The following is a description of a gene set: Systems vaccinology has emerged as an interdisciplinary field that combines systems wide measurements and network and predictive modeling applied to vaccinology. Here we used the systems vaccinology approach to study the molecular mechanisms underlying the innate responses to the trivalent inactivated influenza (TIV) and live attenuated influenza (LAIV) vaccination in humans, and to identify early gene signatures that predict the magnitude of the antibody responses to influenza vaccination. Genes down-regulated in comparison of peripheral blood mononuclear cells (PBMC) from TIV influenza vaccinee pre-vaccination versus that after the vaccination Human Gene Set: GSE29614_CTRL_VS_TIV_FLU_VACCINE_PBMC_2007_DN from publication Nakaya HI, Wrammert J, Lee EK, Racioppi L, Marie-Kunze S, Haining WN, Means AR, Kasturi SP, Khan N, Li GM, McCausland M, Kanchan V, Kokko KE, Li S, Elbein R, Mehta AK, Aderem A, Subbarao K, Ahmed R, Pulendran B (PMID 21743478) species: Homo sapiens, and this is the list of marker genes: ADAMTSL2, CRYBB1, ZWINT, TNFRSF17, GRHL3, CEP162, TCP10L3, ADAMTSL4, SPC24, KIF14, TMEM19, DMBT1, PHF8, CFB, IGLV1-44, PRSS50, RAB40C, ZBTB8A, CEP70, SLC22A1, TEF, KCNIP4, STK31, KIF28P, STATH, PHYHIPL, DNAJC25, RFESD, PRR7-AS1, OXGR1, CAV1, PDZK1, IQCF6, GINS1 (NCBI Gene Id 9837), SDHA, HMMR, FAM98A, RNF170, DDX17, EXTL3-AS1, MIR124-2HG, FABP4 (fatty acid binding protein 4), SLC2A5, FSCN3, SEMG1, GULP1, RBM26-AS1, AURKA, SLC9B1, XBP1, ITM2C, STX19, TYMS, MSX1, SORCS3, EFHC1, CCDC167, ANO4, EMC9, IZUMO1, MRPS7, CFAP300, PLPPR5-AS1, TPD52, SPAG5, DLGAP5, CFAP20, SPATA31E1, KHDC1, ODR4, PALD1, SEC11C, CHAC2, DSN1, ADIPOQ, CEP55, NCAPG, MRPL35, POU4F1, LINC02226, ZC3HAV1L, STEAP1 (NCBI Gene Id 26872), FOXM1, ASIC5, CCNB2, ZNF99 (zinc finger protein 99), HSD17B6, CDK1, IGLV3-19, CPNE4 (copine 4), WWC1, CENPF, BHLHE41, CD38, ENSG00000124835, E2F8, CD1E, NUF2, KIF20A, MZB1, ZNF625, SPIC, MCM2, EXD3, IGLL3P, NTNG1, DTL, CCNB1, H4C9, CDC27, B4GALT3, SRARP, ADD2, OR52A1 (NCBI Gene Id 23538), SMC2, MAGEB18, PURPL, SEMG2, OIP5, PCDH12 (protocadherin 12), PRDM15, PBK, ASB3, HSP90B1, SEC24C, NT5DC2, PARM1, TUBG1, ANKRD16, TMEM168, CNTNAP3, SHROOM2, CABP1, MRPL12, XKR6, HSPA5, ZCCHC2, AMN, SCOC-AS1, IGLJ3 (NCBI Gene Id 28831), BFSP2, EOLA2, ZNF257, BUB1B, GMPPB, TRAM2, CLPTM1L, DENND5B, GLDC, UMODL1, TRIP11, LINC00472, DMGDH, CST1, ZNF22-AS1, SIGLEC6, KIF15, ABRA, SLC25A5-AS1, CDKN3, GUSBP11, RRM2, SHCBP1, MINAR1, PRPF38A, FANCM, TMPRSS11E, LINC00616, GPHB5, GLI2, ABCA8, YTHDF1, TPM4, PCLAF, TAS2R40, PPP4R3C, SAXO2, RGS13, MRPL45P2, LRRC3, PHTF1, AHSA2P, SH2D6, C11orf24, MKI67, SEC61B, RGMB-AS1